Given this list of marker genes TNFRSF19, FADS3, BCL6, GAP43, SYTL2, OSM, CDKL3, FXYD1, MAN2B1, GATA1, RAP1GAP2, GFRA3, CACNA1D, SMARCA1, TMEM132E, VPREB3, MYOG, PLCB3, AGER, DNAJB5, DPYSL2, KRT17, IRF9, MAP2K5, ARHGAP30, QRICH1, IDH1, KPNB1, AAMDC, KRT78, HBEGF, ANKS1B, SV2B, COL2A1, OTX2, SREBF2, HID1, WDR13, CA3, EHBP1, SPI1, TMEM132E-DT, SLC6A4, LDLR, NEUROD2, SKIDA1, STX4, NECAP1, NSRP1, TMEM119, KLF12, TMEM86B, ZBTB18, PDCD10, IP6K2, GNB2, NUDCD1, APBB3, HOXC4, RCOR2, GSE1, E2F1, FBXO24, VCPIP1, ST7, TENT4B, EN1, LINC03040, PPP1R10, MAF, HDX, MYL11, C1QTNF7, TEAD2, VEZF1, ZNF202, VSIG1, CEBPB, SHKBP1, GJB1, ADORA1, SLC7A11, NDUFAF3 (NADH:ubiquinone oxidoreductase complex assembly factor 3), PTHLH, EYA3, TNNT2, SET, KCNJ1, RAB10, DNAJC1, ITPR3, EIF5B, PRKAG1, JAKMIP2, PDGFRB, SLC35A4, MTF1, ADD3, PRELP (NCBI Gene Id 5549), FAM83H, WFIKKN2, LBX1, HOXD10, ZNF710, MAP1A, PDZD4, HCRTR1, GRM6, PAX2, MEX3B, ZFP36L1, NTRK3, DSG1, PPP1R1B, JADE2, CCDC106, PCF11, ITPRIPL1, NT5C3A, GAST, SLC38A5, SERPINI1, AP5B1, TTC16, DYNC1LI1, IER5L, MRPS18B, KCTD15, NOTCH2NLA, PLA2G3, LRP8, KANK2, PROKR1, RSF1 (remodeling and spacing factor 1), ETV5, BLCAP, CLSTN3, RBP5, KLK13, GREM1, AMHR2, MLLT6, SLITRK3, NOTCH2, BAZ2A, STAC3, TBCC, DTX1, NFATC4, APP, FOXRED1, SLC35G3, PRKACA, NUFIP2, CHN2, SAP130, GUCA2B, TLX3, GFAP, TEX2, GADD45G, BCL11A, FNBP1 (formin binding protein 1), EIF4G2, DNMT3B, NIPBL, PEG3, DPT (dermatopontin), POU4F2, UBXN10, ZNF532, NFE2L3, DLG2, DSG3, SEMA3B, TXNDC9, PAMR1, GGNBP2, HYAL1, GARIN4, PAX7, MEX3D, CACNA1A, FBRS, RHOA, UBE3A, MIR137HG, MID1, PPM1E, CLC, SH3KBP1, NDUFS8, LONRF3, HOXB2, NRGN, GRID2, SIK2, LUM, REEP1, RBM24, CEND1 (NCBI Gene Id 51286), RAB30, LGI3, HOXA10, GRN, DCTN1 (dynactin subunit 1), COLQ, IVNS1ABP, INPP4A, GNAO1, HOXC11, RAB33A, FCHSD2, REV3L, C3orf62, EIF1B, HSPA9 (NCBI Gene Id 91471), DDX17, SIPA1, C12orf57 (chromosome 12 open reading frame 57), HSPG2, RNF123, LRCH4, HOXB4, TNNI2, ZIM2, CFAP65, KCNMB1, GRHL2, DALRD3, IGF2BP3, TRIM63, SRCIN1, MST1 (NCBI Gene Id 4485), YWHAQ, ARFGEF1, ADRA1B, NECTIN1, ADCY4, LHX1, ZNF711, DLK2, HCN4, HIPK1, PDP2, ZIC4, ATP6V0C, DHH, SRPRA, TNNI1, HIF1A, EMX2, KMT2E, ELOVL5, ARFGAP2, DDX6, ZIC2, PHF12, here is a description of the gene set: Human Gene Set: SREBP_Q3 Genes having at least one occurrence of the motif VNNVTCACCCYA in the regions spanning 4 kb centered on their transcription starting sites. This matches the transcription factor binding site V$SREBP_Q3 (v7.4 TRANSFAC). studied in species Homo sapiens